Given this list of marker genes Flt1, Plxnd1, Angpt1, Dll4, Ctnnb1, Srf, Kdr, Vangl2, Gbx2, Gdf2, Tbx20, Ednra, Ppp3r1, Notch4, Nrarp, Tgfbr2, Vegfa, Acvr1, Cxcl12, Col4a1, Sema5a, Abl1, Tbx1, Ihh, Gna13, Sfrp2, Nfatc3, Sirt6, Cxcr4, Nrp1, Shh, Stk4, Foxc2, Tek, Fkbpl, Mdk, Sema3e, Fgf8, Ahr, Edn1, Nfatc4, Pitx2, Rbm15, Eng (NCBI Gene Id 99055), Lef1, here is a description of the gene set: Mouse Gene Set: GOBP_BRANCHING_INVOLVED_IN_BLOOD_VESSEL_MORPHOGENESIS studied in species Mus musculus The process of coordinated growth and sprouting of blood vessels giving rise to the organized vascular system.